Given this list of marker genes UMOD, CLDN16, HPRT1, PRPS1, NDUFAF6, EHHADH, PNP, GATM, ALDOB, MOCS1, SLC2A9, SLC22A12 (solute carrier family 22 member 12), MOCS2, SLC34A1, here is a description of the gene set: Abnormal amount of urate in the urine. Human Gene Set: HP_ABNORMALITY_OF_URINARY_URIC_ACID_LEVEL Abnormality of urinary uric acid level studied in species Homo sapiens